Given this list of marker genes Abca7, Ubxn1, Nr1h3, Ufl1 (NCBI Gene Id 67490), Herpud1, Alox5, Ddrgk1, Wfs1, Pdx1, Lrrk2, Akt2 (NCBI Gene Id 76480), Opa1, Pdia6, Syvn1, Lpcat3, Nck1, Usp14, Bcl2l1, Park7, Grina (glutamate receptor, ionotropic, N-methyl D-aspartate-associated protein 1 (glutamate binding)), Hyou1, Txndc12, Prkn, Clu, Creb3l1, Akt1, Bfar, Akt3, Xbp1, Nck2, Sgta, Nr1h2, Aqp11, Ubxn2a, Atad3a, Dnajb9, Selenos, Ptpn1, Svip, Hspa5, Crebrf, Ikbkg, Usp25, Tmbim6, Igtp, Atf6b, Creb3, here is a description of the gene set: Any process that stops, prevents or reduces the frequency, rate or extent of a response to endoplasmic reticulum stress. studied in species Mus musculus Mouse Gene Set: GOBP_NEGATIVE_REGULATION_OF_RESPONSE_TO_ENDOPLASMIC_RETICULUM_STRESS